The following is a description of a gene set: Human Gene Set: HP_GANGLIONEUROBLASTOMA species: Homo sapiens Ganglioneuroblastoma, and this is the list of marker genes: GDNF (glial cell derived neurotrophic factor), KIF1B, PHOX2B, MYO1H (myosin IH), EDN3, LBX1, BDNF